Given this list of marker genes Hic1, Nbn, Pik3cb, Arl6ip5, Prkca (NCBI Gene Id 18750), Trp73, Snw1 (SNW domain containing 1), Bcl2a1b, Ifi204, Nacc2, Hells, Gskip, Gcg, Ero1a, Aldh2, Bak1, Bcl2a1a, Hif1a, Hspb1, Ifi209 (interferon activated gene 209), Zfas1, E2f2, Nlrp1b, Ubqln1, Ei24, Usp15, Hyou1, Sgpp1, Scn2a, Eda2r, Bid, Ankrd2, Bcl2l2, Pias4, Tmbim6, Rpl26, Mlh1, Pmaip1, Armc10, Ripk3, Snai2, Ifi27l2b, Cep63, Ell3, Bcap31, Rrm2b, Qrich1, Adcy10, Fnip2, Apaf1, Pnp, S100a9, Aifm1, Dnaja1, Prkdc, Nkx3-1, Ercc6, Siah1a, Trim32, Ddit3, Rtkn2, Trib3, Nck1, Ackr3, Mdm2, Brca2 (breast cancer 2, early onset), Nono, Tpt1, Parl, Lrrk2, Eaf2, D1Pas1, Ndufs3, Ifi213, Nox1, Selenos, Mdm4, Flcn, Topors, Taf6, Cav1, Brsk2, Chek2, Pdk1, App, Hras, Tnfrsf1b, Becn1, Zfp385a, Ier3, Mbd4, Bad, Tnf, Atf4, Selenok, Pink1, Bcl2a1d, Sh3glb1, Hipk1, Ybx3, Zfp385b, Perp, Coa8, Eno1b, Ddit4, Map2k4, Cdkn1a, Fgf2, Sfpq, Hnrnpk, Pdk2 (NCBI Gene Id 18604), Hip1r, Eif2ak3 (NCBI Gene Id 13666), Rrn3, Cyp1b1, Spop, Muc1, Casp9, Ptpmt1, Snai1, Rps27l, Myc, Il10, Usp47, Atm, Bcl3, Cyct, Shisa5, Bcl2a1c, Gsdme, Ptpn2, Tnfrsf1a, Mybbp1a, Itpr1, Ins2, Aen, Stk24, Tmem109, Park7, Mapt, Mllt11, Htra2, Ube2k, Pik3r1, Mapk7, Gsk3b, Chac1, Epha2, Ppia, Ptgs2, Bcl2l1, Triap1, Atf2, Map2k1, Bmyc, Atp2a1, Bax (NCBI Gene Id 12028), Nck2, Ifi203, Siva1, Ikbke, Bcl2l11, S100a8 (NCBI Gene Id 99591), Akt1, Phlda3, Sod1, Tnfrsf10b, Prkn (parkin RBR E3 ubiquitin protein ligase), Rnf183 (ring finger protein 183), Ivns1abp, Diablo, Rps3, Il20ra, Creb3l1, Casp3, Atad5, Opa1, Sfn (stratifin), Cxcl12, Cdkn2d, Trp53, Plaur, Marchf7, Ern1, Trp63, Bag6, Cdip1, Dnm1l, Hipk2, Gpx1, Ppp1r13b, Dyrk2, Cycs, Txndc12, Src (Rous sarcoma oncogene), Eif2a, Casp6, P4hb, Mif, Ptprv, Skil, Rnf7, Jak2, Vnn1, Creb3, Rnf186, Prodh, Cyld, Eno1, Herpud1, Tmem161a, Serinc3, Rps7, Ndufa13, Sirt1, Msh6, Trap1, Fbh1, Rad9a, Fzd1, Septin4, Dab2ip, Nlrp1a, G2e3, Fyn, Ifi27, Xpa, Kdm1a, Crip1, Bdkrb2, Plscr1, E2f1, Wfs1, Mndal, Bclaf1, Pou4f2, Ppif, Vdac2, Gata4, Moap1, Bub1, Msx1, Daxx, Ppm1f, Mcl1, Ifi214, Tmem238l, Ern2, Epo, Steap3, Kdm6a, Mmp9, Usp28, Mmp2, Prkra, Hint1 (NCBI Gene Id 15254), Plagl2 (NCBI Gene Id 99408), Uri1 (NCBI Gene Id 97390), Melk, Fbxw7, Grina, Syvn1, Hdac2, Lgals12, Cebpb, Fhit (fragile histidine triad gene), Ifi203-ps, Dnajc10, Mapk8ip1, Pdx1, Casp2, Fignl1, Rack1, Stk25, Ubb, Uaca, Knl1, Bcl2l12, Ifi206 (NCBI Gene Id 240921), Ddx3x, Ppp2r5c, Wwox, Ercc2, Lck, Noc2l, Brca1, Clu, Ep300, Pycr1, Xbp1, Nfatc4, Ifi208 (NCBI Gene Id 100033459), Trem2, Bcl2l10, Tmem117, Wnt1, Ctnnb1, Dapk2, Pou4f1, Mtch2, Fbxo7, Fcgr2b, Il19, Tifab, Atp2a3, Ikbkg, Pycard, Hdac1, Nupr1, Parp1, Polb, Bag5, Mael, Siah1b, Bbc3, Bcl2, Bok, Styxl1, Stk11, Nherf1, Casp12, Pttg1ip, Hmox1, Ptpn1, Ifi27l2a, Nfe2l2 (nuclear factor, erythroid derived 2, like 2), Pml, Bnip3, Nol3, Map3k5, Trp53bp2, Erp29, Ddx5, Nme5 (NCBI Gene Id 75533), Msh2, Pdcd10, Sod2, Zfp622, Cd44, Ddias, Rrp8, Fis1, Jmy, Ccar2, Ifi207, Cd74, here is a description of the gene set: species: Mus musculus The series of molecular signals in which an intracellular signal is conveyed to trigger the apoptotic death of a cell. The pathway starts with reception of an intracellular signal (e.g. DNA damage, endoplasmic reticulum stress, oxidative stress etc.), and ends when the execution phase of apoptosis is triggered. The intrinsic apoptotic signaling pathway is crucially regulated by permeabilization of the mitochondrial outer membrane (MOMP). Mouse Gene Set: GOBP_INTRINSIC_APOPTOTIC_SIGNALING_PATHWAY